The following is a description of a gene set: species: Homo sapiens A specialized extracellular matrix that surrounds the plasma membrane of the ovum of animals. The egg coat provides structural support and can play an essential role in oogenesis, fertilization and early development. Human Gene Set: GOCC_EGG_COAT, and this is the list of marker genes: ZP3, ZP4, OVGP1, ZP2, ZP1